Given this list of marker genes 1700025G04Rik, Nrn1, Ptgdr2, Zcchc3, Gja3, Aplnr, Ifnar2, here is a description of the gene set: studied in species Mus musculus Genes predicted to be targets of miRBase v22 microRNA mmu_miR_7071_5p in miRDB v6.0 with MirTarget v4 prediction scores > 80 (high confidence targets). Mouse Gene Set: MIR_7071_5P from publication Chen Y, Wang X (PMID 31504780)